Given this list of marker genes NFKB2, POMP, FCGR2C, GLIS3, LYN, THRB, ITCH, RASGRP1, DOCK11, TSHR, CARD10 (NCBI Gene Id 29775), AIRE, ADA, FOXP3, FOXE1, here is a description of the gene set: Anti-thyroid antibody positivity species: Homo sapiens Human Gene Set: HP_ANTI_THYROID_ANTIBODY_POSITIVITY The presence of autoantibodies (immunoglobulins) in the blood circulation that react against one or more components on the thyroid.